Given this list of marker genes SMAD3, VSIR, CERS6, TCP11L2, PRDX6, CD38, SEC62, MZB1, CAPN5, CD81, TBL2, SSR4 (NCBI Gene Id 6748), CSF2RB, PIP4P2, DNAJB11, GPR108, DPP4, MLX, SLC12A4, ADGRE5, UBAC2, PLOD3, TUBB2A, MANF, GPATCH2, DTWD1, USP16, GMPPA, ZFYVE21, UPB1, RABAC1, ATP1B1, TMEM62, FOXO3, STARD3NL, ALG11, TAPBPL, SLC31A1, IFT46, EIF4E3, ATP5MC1, NPLOC4, EMC7, RCN1, RRBP1, CCPG1, CDK5RAP3, ITFG1, CACFD1, RPN1, TLR2, SLC37A3, IGKC, IRGM, NARS1, ABCB6, TMEM120B, RELN, ELOA, SLA, ARL14EP, ACADVL, PRLR, GAS2L1, TRPT1, CHST1, TBC1D7 (NCBI Gene Id 51256), PNPO, ST8SIA4, TPST1, SELPLG, ERGIC3, PIGK, LMAN1 (lectin, mannose binding 1), TMEM248, GPR180, ZMYND11, PPIB, DERL2, AMIGO2, TXNDC15, SRP68, MOGS, PML, ANKRD6, ATG9A, ATF6, SLC10A3, SARAF, COPZ1, SGCB, SRP72, DNAH12, CDC34, NUS1, EVC, ALCAM, B4GALT1, GDAP2, SSR1, IFNAR2, TET2, GALE, NUCB1, GMPPB, EMP3, RNF13, S100A10, PDIA6 (NCBI Gene Id 10130), GPR89B, PLCXD2, TMEM39A, TENT5C, PJA2, SLPI, DCAF1, PRDX4, PDLIM5 (PDZ and LIM domain 5), TMEM214, PPP3CC, TXNDC11, MAN2A1, KDELR1, KDELR2, MORF4L2, ALDH3B1, HS2ST1, C15orf39, SCFD2, NODAL, DNAJC3, STARD5, TMED10, EDEM3, SRPRA, HSD11B1, SLC35B1, RWDD2A, PSAP, HSPA5, YIPF3, MALAT1, CCNE1, NOMO1, LRRC59, ALG1, FTL, EVI2A, GPR19, ALPL, MGAT2, RILPL2, HSPA13, LINC01160, SLC48A1, SMPD1, USO1, GSTO1, CERS2, VKORC1L1, RCBTB2, DHDDS (dehydrodolichyl diphosphate synthase subunit), SPCS1, CD44, ATOSA, IQGAP2, GFPT1, ATXN1, NPC2, RNF187, NCEH1, TMX1, NPTX2, VCP (valosin containing protein), IFRD2, PEPD, NEK6, COQ9, ARSB, LAPTM4A, UBL3, MLLT3, TMCO1, MPC2, UBE2J1, DERL3, ST3GAL1, TBC1D25, SVIL, ERLEC1, CANX (calnexin), SIX5, CD1D, CAPG (NCBI Gene Id 822), PLPP5, PSME4, PRKCSH, GALNT2, TRAM2, LMAN2, here is a description of the gene set: species: Homo sapiens Genes up-regulated in T reg: IKZF4 versus wildtype. The transcription factor FoxP3 partakes dominantly in the specification and function of FoxP3+ CD4+ T regulatory cells (Tregs), but is neither strictly necessary nor sufficient to determine the characteristic Treg transcriptional signature. Computational network inference and experimental testing assessed the contribution of several other transcription factors (TFs). Enforced expression of Helios or Xbp1 elicited specific signatures, but Eos, Irf4, Satb1, Lef1 and Gata1 elicited exactly the same outcome, synergizing with FoxP3 to activate most of the Treg signature, including key TFs, and enhancing FoxP3 occupancy at its genomic targets. Conversely, the Treg signature was robust to inactivation of any single cofactor. A redundant genetic switch thus locks-in the Treg phenotype, a model which accounts for several aspects of Treg physiology, differentiation and stability. Human Gene Set: GSE40273_EOS_KO_VS_WT_TREG_UP from publication Fu W, Ergun A, Lu T, Hill JA, Haxhinasto S, Fassett MS, Gazit R, Adoro S, Glimcher L, Chan S, Kastner P, Rossi D, Collins JJ, Mathis D, Benoist C (PMID 22961053)